Given this list of marker genes Rbm7, Ropn1l, Eomes, Coasy, Gmfg, Elavl1, here is a description of the gene set: species: Mus musculus Genes predicted to be targets of miRBase v22 microRNA mmu_miR_3073b_3p in miRDB v6.0 with MirTarget v4 prediction scores > 80 (high confidence targets). from publication Chen Y, Wang X (PMID 31504780) Mouse Gene Set: MIR_3073B_3P